The following is a description of a gene set: Human Gene Set: HP_VIRAL_INFECTION_INDUCED_RHABDOMYOLYSIS Viral infection-induced rhabdomyolysis studied in species Homo sapiens Rhabdomyolysis induced by a viral infection., and this is the list of marker genes: MT-CO1, TSEN54, TSEN2, OBSCN, ALDOA, TSEN34 (tRNA splicing endonuclease subunit 34), LPIN1, SEPSECS (NCBI Gene Id 51091), MT-CO3, TSEN15, DGUOK